The following is a description of a gene set: Mouse Gene Set: GOMF_PROTEIN_ARGININE_OMEGA_N_MONOMETHYLTRANSFERASE_ACTIVITY species: Mus musculus Catalysis of the addition of a methyl group to either of the unmethylated terminal nitrogen atoms (also called omega nitrogen) in peptidyl-arginine to form an omega-N-G-monomethylated arginine residue. The reaction is S-adenosyl-L-methionine +-L-arginine = S-adenosyl-L-homocysteine +-Nomega-methyl-L-arginine., and this is the list of marker genes: Prmt1, Prmt3, Prmt7, Prmt8, Prmt6